Given this list of marker genes ACADS, CTNS, MCCC1, MMUT, NFU1, here is a description of the gene set: studied in species Homo sapiens Human Gene Set: HP_EPISODIC_METABOLIC_ACIDOSIS Repeated transient episodes of metabolic acidosis, that is, of the buildup of acid or depletion of base due to accumulation of metabolic acids. Episodic metabolic acidosis